Given this list of marker genes Rack1, Fxyd5, Ptms, Gnai3, Serpine2, H2-D1, Rplp1, Laptm5, Neat1, Manf, Irf2bp2, Psmb8, Dstn (destrin), Tmed10 (NCBI Gene Id 68581), Lrrc58, Rpl13a, Rps9, H2-K1, Uba5, here is a description of the gene set: studied in species Mus musculus Mouse Gene Set: TABULA_MURIS_SENIS_LUNG_PULMONARY_INTERSTITIAL_FIBROBLAST_AGEING from publication Tabula Muris Consortium (PMID 32669714)